The following is a description of a gene set: studied in species Homo sapiens The directed movement of spermidine, N-(3-aminopropyl)-1,4-diaminobutane, a polyamine formed by the transfer of a propylamine group from decarboxylated S-adenosylmethionine to putrescine, into, out of or within a cell, or between cells, by means of some agent such as a transporter or pore. Human Gene Set: GOBP_SPERMIDINE_TRANSPORT, and this is the list of marker genes: SLC22A1, SLC22A3, SLC22A16, SLC22A2, SLC18B1